The following is a description of a gene set: Posterior positions and/or vertical shortening of the infraorbital and perialar regions, or increased concavity of the face and/or reduced nasolabial angle. Human Gene Set: HP_MIDFACE_RETRUSION studied in species Homo sapiens Midface retrusion, and this is the list of marker genes: WNT5A, POGZ, YME1L1, HSPG2, MMP23B, PRDM16, KAT6A, LRRC32, POP1, SPEN, CAMK2B, TMEM165, TBL1XR1, FLII, EPB41L1, H3-3A, HSPA9, FAM50A, NEPRO, SMAD2, RAB3GAP2, TUBGCP2, TBX1, MAD1L1, DVL3, LHX3, NKAP, TCF12, LZTR1, POLR1D, BPTF, CDC42, LUZP1, KMT2D, ZBTB20 (NCBI Gene Id 26137), FAM20C, SERPINH1, MED13L, SEC23A, TCOF1, COG1, SOS1, DDB1, PYCR1, ATP6V0A2, CILK1, TRIO, MN1, NRAS, COX7B, RAC3, FZD2, SOX11 (NCBI Gene Id 6664), PAK2, TMCO1 (transmembrane and coiled-coil domains 1), BRF1, NFIX (NCBI Gene Id 4784), AIFM1, LEMD2, RIT1, HEPACAM, TCF20 (NCBI Gene Id 6942), WDR35, SMCHD1, TSR2, IL11RA, RAB23, PRR12, FGFR2, GRIN1, LTBP4, GABRD (gamma-aminobutyric acid type A receptor subunit delta), H3-3B, PTCH1, EBP, COL27A1, DCHS1, FIBP, HESX1, POLR1A, PSMC1, IREB2, RERE (NCBI Gene Id 9642), CTSK (NCBI Gene Id 1513), POR, CCDC47, CBL, SIX3, PLP1, DEAF1, BMP2, B4GALT7, SLC9A7, MRAS, COL18A1, RAI1, ZNF407, SMC1A, ELN, MEGF8, PRKAR1A, DLX4, RRAS, KMT2C, IQSEC2, LINS1, DEPDC5, KCNQ1, SOS2, RAP1B, SLC26A2, SLC35D1, MYSM1, COL9A3, PTPN11, BUB1B, PDPN, EHMT1, PPP2R5D, RFWD3, UFC1, SATB1, WDR26, BICD2, AGL, LRPPRC, COL11A2, H19, CDKN1C, MRPS14, LMNA, SPRED2, ACTB, SP7, KRAS, PRKACA, SEC24D, IARS2, SON, LIFR, POU1F1, ROR2, FGFR1, POLR1C, COL9A2, SATB2, TSEN54, CASZ1, COL11A1, CRTAP, ZFX, WASF1, MTOR, AMPD2, HCCS, MBD5 (methyl-CpG binding domain protein 5), POMGNT1, PKD2, MGP, MAF, ALG12, PEX1, RPS28, UBE2A, OTUD5, BMP4, GDF11, STAC3, RRAS2, PSMD12, FOXG1, SH2B1, KIF22, COL2A1, FAT4, DDR2, IFT81, ATRX, CLCN3, TRPM3, DPH5 (NCBI Gene Id 51611), LRP2, ADNP, BANF1, TLK2, CSGALNACT1, HNRNPH2, ACAN, KCNQ1OT1, NDUFB11, RAF1, KCNAB2, PDE4D, RAB3GAP1, TGFB3, LBR, CDK19, AMMECR1, OBSL1, MLXIPL, RNU12, GNPAT, CTCF, PTH1R, CEP120, SETBP1, B3GAT3, MIR140, NGLY1, BCL11A, ITCH, SMAD4, PITX2, FLNA, MESD, ANKRD17, GMNN, OSGEP, POLR1B, CDH11, ZIC1, SLC25A24, KIF15, DHX37, FGFR3, HOXB1, FLNB, GHR, CPLX1, NECTIN1, GLI2, ACP5, HECW2, EFTUD2, SLC6A8, SF3B4, HDAC4, B3GALT6, PDGFRB, RUNX2, CCDC8, CUL7, UBE4B, FGD1, TONSL, MIPEP, PRKCZ, PIGV, SHH, PROP1, SOX9, RYR1, CHD3, USB1, NF1, ANTXR1, RASA2, ZNHIT3 (NCBI Gene Id 9326), WDR73, ZMIZ1, CHD1, DSE, NXN, PTRH2, PIK3R1, IFT52, NSMCE3, WAC, GRIA4, MAN2B1, BICRA, COX15, JARID2, DVL1, LHX4, CHST3, GPC4, CANT1, P4HB, SKI, TWIST1, CLCN4, FOXC1, FBN1, MECP2, RNF13, KDM6A, IGF2, COL1A1, SOST, PTEN (phosphatase and tensin homolog), ERF